The following is a description of a gene set: Human Gene Set: SIG_BCR_SIGNALING_PATHWAY studied in species Homo sapiens Members of the BCR signaling pathway, and this is the list of marker genes: CD22, CD19, PDPK1, SYK, MAPK1, ITPR2, AKT3, NR0B2, PIK3R1, PIK3CA, AKT1, SOS2, MAPK3, BCR, NFATC1, PPP3CA, DAG1 (dystroglycan 1), PPP3CC, CD81, FLOT2 (NCBI Gene Id 2319), INPP5D (inositol polyphosphate-5-phosphatase D), CSK, PIK3CD, ITPR3, GRB2, VAV1, SOS1 (SOS Ras/Rac guanine nucleotide exchange factor 1), RAF1, GSK3A, LYN, SHC1 (SHC adaptor protein 1), MAP4K1, ITPR1, FLOT1, BLNK, GSK3B, BTK, NFATC2, BCL2, PPP3CB, AKT2, CR2, PPP1R13B, PTPRC, PLCG2, BAD